The following is a description of a gene set: species: Homo sapiens Abnormal relationship Human Gene Set: HP_ABNORMAL_RELATIONSHIP The state of having abnormal relationships with others. This does not describe specific aspects of one's social aptitudes but rather a state which may come about from these aptitudes, such as lacking peer relationships, lacking close friends, or having a relational network that is abnormal given one's cultural context., and this is the list of marker genes: AP2M1, SCN1A, CHD2, SH2B1, SLC2A1, NEXMIF, EXTL3, TRIM8, NLGN3, GFM2, IQSEC2, NLGN4X, SYNGAP1, ACOX1, MECP2, SLC6A1